The following is a description of a gene set: studied in species Homo sapiens Human Gene Set: HP_COMPENSATORY_HEAD_POSTURE A compensatory head posture occurs when the head is deviated out of the normal primary straight head position in order to compensate for an ocular problem. Compensatory head posture, and this is the list of marker genes: TUBA1A, GPR179, PDE6B, CACNA2D4, LRIT3, RHO, TUBB3 (tubulin beta 3 class III), SALL4, TUBB2B, PHOX2A, SAG, TRPM1, SLC24A1, GRM6, NYX, GRK1, CHN1, CACNA1F, CABP4, COL25A1, GNAT1, GNB3, KIF21A, MAFB